Given this list of marker genes SOS2, PTPN11, SOS1, GRB2, SHC4, SHC2, SHC1, SHC3, GAB2, GAB1, here is a description of the gene set: Pathway Definition from KEGG: (PTPN11,SHC,GAB,GRB2) -> SOS studied in species Homo sapiens Regulation of GF-RTK-RAS-ERK signaling pathway, adaptor proteins. Pathway ID: N01595. Pathway type: Reference. Pathway class: nt06526 MAPK signaling. Human Gene Set: KEGG_MEDICUS_REFERENCE_REGULATION_OF_GF_RTK_RAS_ERK_SIGNALING_PATHWAY_ADAPTOR_PROTEINS